Given this list of marker genes PDIA4, SPRING1, CEACAM8 (CEA cell adhesion molecule 8), DEFA1B, ZFP30, TNFRSF17, SNORD3C, WFS1, here is a description of the gene set: studied in species Homo sapiens Genes up-regulated in blood 7d vs 0d in children (0.5-14y) after exposure to Fluzone, time point 7D. Comment: ~80% of cohort were white, ~50/50 Female:male Human Gene Set: CAO_BLOOD_FLUZONE_AGE_05_14YO_7DY_UP BACKGROUND: Live attenuated influenza vaccine (LAIV) and trivalent inactivated influenza vaccine (TIV) are effective for prevention of influenza virus infection in children, but the mechanisms associated with protection are not well defined. METHODS: We analyzed the differences in B-cell responses and transcriptional profiles in children aged 6 months to 14 years immunized with these 2 vaccines. RESULTS: LAIV elicited a significant increase in naive, memory, and transitional B cells on day 30 after vaccination, whereas TIV elicited an increased number of plasmablasts on day 7. Antibody titers against the 3 vaccine strains (H1N1, H3N2, and B) were significantly higher in the TIV group and correlated with number of antibody-secreting cells. Both vaccines induced overexpression of interferon (IFN)-signaling genes but with different kinetics. TIV induced expression of IFN genes on day 1 after vaccination in all age groups, and LAIV induced expression of IFN genes on day 7 after vaccination but only in children < 5 years old. IFN-related genes overexpressed in both vaccinated groups correlated with H3N2 antibody titers. CONCLUSIONS: These results suggest that LAIV and TIV induced significantly different B-cell responses in vaccinated children. Early induction of IFN appears to be important for development of antibody responses. from publication Cao RG, Suarez NM, Obermoser G, Lopez SM, Flano E, Mertz SE, Albrecht RA, García-Sastre A, Mejias A, Xu H, Qin H, Blankenship D, Palucka K, Pascual V, Ramilo O (PMID 24495909)